Given this list of marker genes PPP4R4, PPM1L, PABIR3, DUSP13B, PPM1M, RCAN1, PPP6C, DUSP18, PPP1CB, DUSP16, CTDSP1, PPP1R14A, CDKN3, DUSP6, LCK, SSU72L5, PPP1R14D, PPP2CA, BCKDK, PPP5C, MYH6, CPPED1, PPP3R2, SSH2, PP2D1, DUSP9, PPM1H, CTDSPL2, PABIR1, DUSP22, PPM1K, CTDNEP1, DUSP4, PPP1R3D, PPM1G, PPA2, DUSP15, FIG4, PABIR2, PPM1B, PPTC7, PHLPP1, PPM1E, DUSP23, CDC14B, SSU72L1, SSU72L4, UBLCP1 (NCBI Gene Id 134510), EPM2A, PDP2, DUSP26, PPM1N, DUSP21, PPP1CC, MTMR4, MYH8 (NCBI Gene Id 4626), MYOZ1, DUSP28, PGAM5, PPP3CC, PPP1R12A, PTEN, DMPK, MYH3, PPP1R11, SSU72L3, PPP2CB, DUSP2, CDC14A, PPP1R14B, MTMR14 (myotubularin related protein 14), PPM1F, CTDP1, SSH1, PPP3CB, ILKAP, EYA1 (EYA transcriptional coactivator and phosphatase 1), TIMM50, DUSP8, DUSP12, PPP1CA, PPP1R16B, TPRN, PPP3R1, DUSP19, PPEF2, PPP1R1A, PPP4C (protein phosphatase 4 catalytic subunit), DUSP3, PDXP, CDC14C, SSU72L6, PPM1D, DUSP1, MTMR6, PPM1J, PPP1R12B, DUSP13A, CTDSPL, DUSP7, PPP1R3C, RPAP2, MTMR3, PPP1R12C, SSU72, PPP1R14C, SSU72L2, PPP3CA, PPP1R8, PPEF1, PPP2R1A, PTPMT1, DUSP5, PPP1R16A, PHLPP2, CTDSP2, DUSP29, PPP1R17, DUSP10, PPP1R2, DUSP14 (dual specificity phosphatase 14), PPM1A, RCAN3, CAMK2G, PDP1, RCAN2, SSH3, TAB1, here is a description of the gene set: Human Gene Set: GOMF_PROTEIN_SERINE_THREONINE_PHOSPHATASE_ACTIVITY studied in species Homo sapiens Catalysis of the reaction: protein serine phosphate + H2O = protein serine + phosphate, and protein threonine phosphate + H2O = protein threonine + phosphate.